The following is a description of a gene set: from publication Wang Z, Iwasaki M, Ficara F, Lin C, Matheny C, Wong SH, Smith KS, Cleary ML (PMID 20541704) Acute leukemias induced by MLL chimeric oncoproteins are among the subset of cancers distinguished by a paradoxical dependence on GSK-3 kinase activity for sustained proliferation. We demonstrate here that GSK-3 maintains the MLL leukemia stem cell transcriptional program by promoting the conditional association of CREB and its coactivators TORC and CBP with homedomain protein MEIS1, a critical component of the MLL-subordinate program, which in turn facilitates HOX-mediated transcription and transformation. This mechanism also applies to hematopoietic cells transformed by other HOX genes, including CDX2, which is highly expressed in a majority of acute myeloid leukemias, thus providing a molecular approach based on GSK-3 inhibitory strategies to target HOX-associated transcription in a broad spectrum of leukemias. Human Gene Set: WANG_RESPONSE_TO_GSK3_INHIBITOR_SB216763_DN Genes down-regulated in RS4;11 cells (MLL, mixed lineage leukemia) in response to SB216763, an inhibitor of GSK3B. species: Homo sapiens, and this is the list of marker genes: DISP2, NDRG1, H4C2, GINS1, POLE2, HERPUD1, TFAM, ZWINT, PSAT1, HSPA1B, TK1, ALDH1A3, EAPP, RB1CC1, MCM10, SCD, IL1RAP, CCNE2, PPP1R27, ECE1, CLSPN, MATK, UBE2T, CENPU, KIF21B, GGT5, FUT7, KNSTRN, C1DP3, ARHGAP44, TIMP3, EXOSC5, BLM, DARS2, SYT2, MCM8, SHCBP1, GABPA, TYMS, CTDSPL, IGLL3P, NLRP3, RANBP1, COQ8A, WDR4, DLX1, JPT2, TRIP13, PDK1, GINS4, MASTL, BEX1 (brain expressed X-linked 1), DHCR7, IDI1, SPC25, TFDP2, POLA1, MAD2L1, DHFR, CCDC28A, KNOP1, TIPARP, CDC6, TOE1, NOL6, MSH2, EZR, DPH2, ACSL3, SPIN4 (NCBI Gene Id 139886), TUBA4A, RRM2, LDLR (low density lipoprotein receptor), FOXJ3, DIAPH3, UTP15, RAD54L, RAD51, GINS2, LMO2, PDGFA (platelet derived growth factor subunit A), MRPS12 (mitochondrial ribosomal protein S12), BUB1B, CD180, LGALS12, SLC1A4, SNRPG (small nuclear ribonucleoprotein polypeptide G), BICDL1, ANKRD18DP, CITED2, ETV5, SERPINB8, F2RL3, H2AZ1 (NCBI Gene Id 3015), MCM5, NOP16, ASF1B, CDC42EP3, TWNK, CEP76, FKBP4, MELK, SLC2A5, CCR2, WT1, PUS7, GMFG (NCBI Gene Id 9535), ETV4, SLC38A5, LYAR, CCM2, MAF1, ORC6, CIP2A, RASGRP2 (RAS guanyl releasing protein 2), GNB4, ARL4C, CCDC26, STMN1, FAM32A (NCBI Gene Id 26017), RRP12, CHAF1A, FADS2, SLC2A3, LAS1L, SEH1L, TRMT10C, CABLES1, SLC39A14, PIM1, CYP51A1, ST8SIA4, CTPS1, DENND11 (NCBI Gene Id 57189), CDC25A, BUB1, RAD51AP1, SUV39H1, MOB3A, BRIP1, SLC25A19, ALDH1B1, DNAJC19, HSP90AA1, RFC2, APBB1, H2AC4, ATG101, HSPE1, NCF1, H3C12, FAM136A, EEF1AKMT1 (EEF1A lysine methyltransferase 1), KNL1, LPCAT1, ELOA (NCBI Gene Id 6924), ACAT2, DKC1, PAIP2, RNF144A, JADE2, DBN1 (drebrin 1), ACY1, ENSG00000293349, TSR1, EBP, DTL, FABP5, IGFBP4, PLXNA1, NUDT5, MIF (NCBI Gene Id 4282), PRXL2B, HNRNPAB, INSIG1, DNAJA1, IPO11, CENPV, WDR48, RUVBL1, CKS1B, SUN2, FASN, RANBP1P1, MYC, DUSP6, RNMT, SLC2A1, PBK, ARRB1, LRP8, MTBP, PLK4, ISYNA1, RHBDL3, NHERF1, NUF2, CD151, CDC45, SLC38A2, HMGCS1, PNO1, GOLGA8IP, EXOSC4, GPT2, ATAD3B, HMGB3, LY6E, SLC6A6, DERL3, GK, KIF22, EGR1, ALOX12, UMPS, MCM3, TGFBR1, MCAT, POLR3H, PFKP, TICRR, URB2, LACC1, HSPA1A, TDRKH, HSPH1, SLCO4A1, BRCA1, CENPK, HDHD5, PHLDA1, SIGLEC12 (sialic acid binding Ig like lectin 12), TFRC, TLE4, PIM2, SDF2L1, XRCC2, MCM7, MYBL2 (NCBI Gene Id 4605), ITGA4, EIF4EBP1, RPS6KA5, UNG, KLHDC3, PIGW, PIH1D1, TNF, PKMYT1, DCUN1D5, ERO1A, SNORD14C (small nucleolar RNA, C/D box 14C), SQLE, EXO1, IL3RA, MSMO1, TSFM, ALYREF, TBC1D15, WT1-AS, TENT5C, CENPM, TAF4B, SEL1L3, CCR1, CASTOR2, ITGA5, CDCA4, SLC27A2, UHRF1, CHAF1B, NCS1, ANKRD28, GART, HSPA4L, SMC2, H1-5, RFC3, C1DP2, TLR2, TFB2M, PTPN7, CCNA2, E2F2, SLC7A5, AHSA1 (NCBI Gene Id 10598), C11orf58, MCM2, DDIAS, RFWD3, PALS2, MCM4, RRP7A, MIR155, TIPIN, MRTO4, CHST11, H1-4, FOS, H2AC13, MCM6, SINHCAF, EMP2, NIP7, ACSL1, PTTG1, TCTN2, PRPS1, NCAPD3, ZNF367, CYTIP, ESCO2, PREB, NHP2, PYCR3, KIF23, CDK2, ACTL6A, SLC16A1, DHCR24, CENPH, WEE1, SNORD14E, GMNN, E2F7, NCAPG, KCNN4, CCPG1, FEN1, DHFRP3, RAB18, NASP, MOCS3, KLHDC2, UBALD2, E2F8, TCF19, B4GALT2, XBP1, ARHGAP21, H2BC3, GABPB2, EIF5AL1, CCNE1, LBR, GINS3, TEX30, PELI2, TNFAIP3, BYSL, RNF122, ITGB5, DCTPP1 (NCBI Gene Id 79077), GEMIN4, UBALD1, GMEB1, EBNA1BP2, MSH6, PDCD4, H2AX, H2BC14, SPC24, SFXN1, PSMC3IP, MSN, PTPRE, DSCC1, EHD1, ATAD2, RFTN1, CD38, HELLS